The following is a description of a gene set: Any process involved in the maintenance of an internal steady state of acylglycerol within an organism or cell. species: Mus musculus Mouse Gene Set: GOBP_ACYLGLYCEROL_HOMEOSTASIS, and this is the list of marker genes: Angptl3, Gip, Fundc2b, Hnf4a, Apoe, Apoa4, C1qtnf3, Apoc2l, Gckr, Gpihbp1, Scarb1, Fitm2, Abcg8, Mtln, Slco1a6, Ldah, Osbpl8, Apoc2, Sesn2, Nr1h3, Dgat2, Apoa1, Apoc3, Rora, Adora1, Med13, Mia2, Slc25a27, Pla2g12b, Apoa5, Abcg5, Apoc4, Angptl4, Lpl (lipoprotein lipase), Il18, Xbp1, Map2k1, Pnpla8, Nr1h4, Fundc2, Angptl8, Pnpla2, Sirt1, Lipc